Given this list of marker genes CYCS, SEPTIN4, CASP7, CASP9, DIABLO, CASP3, XIAP, APAF1, here is a description of the gene set: Once released from the mitochondria, SMAC binds to IAP family proteins displacing them from Caspase:IAP complexes liberating the active caspases. part of: Apoptotic factor-mediated response Reactome Pathway: SMAC, XIAP-regulated apoptotic response species: Homo sapiens